The following is a description of a gene set: Binding to a dynein complex, a protein complex that contains two or three dynein heavy chains and several light chains, and has microtubule motor activity. species: Mus musculus Mouse Gene Set: GOMF_DYNEIN_COMPLEX_BINDING, and this is the list of marker genes: Apc, Hdac6 (NCBI Gene Id 20374), Cenpf, Pafah1b1, Snca, Smc3, Cfap100, Katna1, Dnaaf1, Tpr, Atmin, Cfap73, Katnb1, Gpsm2, Numa1, Kash5, Ppp1r42, Fmr1, Rab29, Fbxw11, Gsk3b, Dctn6, Bicd1, Bicd2